Given this list of marker genes PPARG, CYP24A1, ABCB4, CYP7A1, NR1I3, MIR33A, RARG, VDR, CYP2B6, CYP3A4, CYP26A1, ABCB11, CYP2E1, RARB, MIR33B, CYP8B1 (cytochrome P450 family 8 subfamily B member 1), CYP1A2, NR1H3, ABCC2, ABCD3, RARA, CYP4A11, ABCG5, ABCD2 (NCBI Gene Id 225), ABCC3, PPARA, ABCB1, NR1I2, CYP27B1, CYP4B1, PPARD, NR1H4, ABCA1, ABCG1, CYP2C9, here is a description of the gene set: Nuclear receptors in lipid metabolism and toxicity Human Gene Set: WP_NUCLEAR_RECEPTORS_IN_LIPID_METABOLISM_AND_TOXICITY species: Homo sapiens